The following is a description of a gene set: studied in species Homo sapiens Human Gene Set: HP_ABNORMAL_RESPIRATORY_SYSTEM_MORPHOLOGY Abnormal respiratory system morphology A structural anomaly of the respiratory system., and this is the list of marker genes: FSHR, CLCA4, CRIPTO, HLA-DRB1, RSPO1, SNRPN, PIK3R1, TBC1D8B (NCBI Gene Id 54885), CCND1, ZAP70, NELFA, CCN2, AIRE, DDX3X, NDUFB10, ZCCHC8, PIEZO2, NME5, TET2, PWRN1, SLC12A6 (solute carrier family 12 member 6), FLII, FCSK, TONSL, TRPV3, IFNGR1, AFF4, EVC, GCLC, OCA2, CHRM3, HPS6, FLNB, IL17F, WRAP53, KPTN, NUP205, ELANE, SHH, SP110, ATP6V1B2, SLC26A4, NIN, PSMB9, SCNN1A, TMCO1, CCNQ, UGP2, NIPAL4, FLCN, LMNB1, NLRP1, CCR2 (C-C motif chemokine receptor 2), DPAGT1, RREB1, REN, FBN2, HIRA, KIF20A, POLR2A (NCBI Gene Id 5430), HEY2, PKHD1, DLK1, KCNMA1, PSMD12, WBP11, EDN1, KLF1, PIGO, MDM2, PIGQ, DTYMK, SLC5A7, POLR1A, COL3A1, PRKACA, MYPN, MBTPS2, XPNPEP2, DIS3L2, MCM4, LIPN, MIR140, BMPER (NCBI Gene Id 168667), PEX1, SERPING1, PDGFRB, ARHGAP31, DSG1 (desmoglein 1), EWSR1, TAF1, GLB1, MLH1, PON2, SOX2, RIPK1, NEK9, PON1 (NCBI Gene Id 5444), PLVAP, DDX59, SNAI2, TRIM37, LIMK1, MRAP, COL5A2, BRIP1, EPHB4, KAT6A, SPINK1, BCL6, CD19, RIT1, BRCA1, FANCM, PRPH, POT1, CFH, SLC39A7 (NCBI Gene Id 7922), OCRL, GRIP1, SIAH1, MAGI2, LETM1, TCEAL1, SAT1, TP73, EMC1, PSAP, MANBA, PMS2, NEU1, OSTM1 (osteoclastogenesis associated transmembrane protein 1), VPS33A, ARPC1B, ERCC3, RNU4-2, PLCH1, TBC1D24, DPYSL5 (NCBI Gene Id 56896), POLR3A, POLE, NKX2-1, UFC1, STRA6, RPS15A, TRIM2, FGF20, MST1R (NCBI Gene Id 5755), ZNF341, TRAIP, SLC25A1, KMT2C, MAP3K7, MASP2, GAS8, MAP3K14, PRPS1, TCF3, ALX3 (NCBI Gene Id 93575), ABCA3, ETFA, NFASC, GIMAP5, CFAP74, BTNL2, ALPL, BLNK, CD3E, SPP1, PALB2, NOTCH1, CTSC (NCBI Gene Id 50958), LBR, SLC34A1, IL6R, CTNNBL1, TRIM8, VPS37D (NCBI Gene Id 171020), TNFRSF9, AGTR1, LPIN2 (lipin 2), ZNFX1, IRAK4, LRP12, RMRP, GRHL3, TRAF3IP1, PIGT, TMEM270, MPEG1, IL7R, PRKAR1A, SLC34A2, DAW1, DCLRE1C, SPEF2, SMC1A, ATXN2, DMXL2, FARSA, FCGR2A, PAX2, CEBPE, REST, RIN2, NKX2-6 (NCBI Gene Id 137814), WNT3, SCAF4, PRG4, GBA1, CCR1, H19, BRF1, FADD, ACE, MSN (moesin), SCN4A, DGCR2, PAK2, ARID1A, MARS1, ZIC2, CLPB, CR2, ATP6V0A2, CD2AP, CD46, KIAA0319L, EXTL3 (exostosin like glycosyltransferase 3), POU6F2, DPM2, CDKL5, ERCC4, PLEC, KDM6A, UFD1, DNAJB4, CHD6, GRIA1, COMT, FCGR2B, CSF2RB, KCNN4, VPS35L, IL23R, LRPPRC, AGGF1, ITGA8, TAOK1, MED12, LOX, RIPPLY2 (ripply transcriptional repressor 2), PIK3CA, IL17RC, CEP120, FLNC, FUCA1, ELF4, PIGA, ALG3, KIAA0753, NDN, NUP214, DEAF1 (NCBI Gene Id 105376508), TPM3, IL12A-AS1, MYD88, PRTN3, NME8, CTNNA2 (NCBI Gene Id 1496), SLC18A3 (solute carrier family 18 member A3), YARS1, CD79A, CNTN1, IL17RA, RAP1B (RAP1B, member of RAS oncogene family), SGCG, AGA, MRPS22, AGR2, AASS, FKBP6, MAPK1, TNNT2, KCNA1, SBDS, SMCHD1, EGFR, TBX4, SCN9A, IFT140, MSH6, EIF4A3, NOD2, DNAAF2, PTCH1, PAX3, MYO1E, DEPDC5, EPCAM, CFTR, SNORD116-1, DHCR24, LFNG, WRN, F12, GSTM3, DNASE1, CCDC22, GPC4, CLIP2, ERF, ARNT2, MEFV, ADAMTS19, CD40LG, HYLS1, PET117, DNAAF11, SPI1, FOCAD, NSD1, CSF2RA, NCF2, ACTA1, PMM2, DYNC2I2, NCKAP1L (NCBI Gene Id 3071), HGSNAT, ALDH1A2, UNG, SLC6A14, SLC11A1, TFG, SEMA3E, BACH2, SPTBN1, RSPH9, NTRK1, ERCC6, MMP1, UMPS, SPIDR, DNASE1L3, TIMM8A, TUBG1, JAGN1, MID1, GLMN, DICER1, PRDM10, H4C5, TXNDC15, TBC1D23, FBXO11, BUB3, SH2D1A, PPARGC1A, PIK3CG, CDT1, GIPC1, MGAT2, FGFR3, LTBP1, SMAD3, CD8A, SMN1, COQ8B, SERPINA1, SLC46A1, TBX1, SDCCAG8, NECTIN1, OPTN, RERE, POLD1, GUSB, MEIS2, SMARCD1, UBA2, BTK, CREBBP, BUD23, IFNG, HMOX1, AP3B1, EHMT1, IQSEC2, KIF21A, CDON, MIF, FAS, PRNP, CUX1, LMNA, MGP, STX1A, KIF11, FGFR1, SNAP25, NADK2 (NAD kinase 2, mitochondrial), LTBP3, TNFRSF1A, SNORD115-1, CARD10, IRF1, NPHS1, ARX, APOL1, ALMS1, RSPRY1, GMNN, SCN10A, POR, SOX11, CAV1, ADAMTS3, GLUL, C2CD3 (C2 domain containing 3 centriole elongation regulator), CACNA1C, TNFRSF13B, SKIC3, SHROOM4, SATB1, DGCR6, MYH6, DOCK8, IL2RG, IGBP1, TAF15, TGFBR1, DNAH1, CLEC7A, SCN1B, IGLL1, CACNA1B, BGN, SLC7A7, EDA, TAP2, TBL2, CALCRL, NLRP12, PMS1, CXCR4, PRKG1, IDH1, ANG, ACTN4, UBE2A, USB1, PSMC3IP, SOX3 (SRY-box transcription factor 3), TTC21B, TSPYL1, EXT1, TBX20, ALG9, LZTR1, NEFH, ESS2, IRF5, FUS, DNAAF5, VAMP1, TYR, ACBD6, MYO9A, KRAS, NR5A1, PTPRO (NCBI Gene Id 5800), DNAJC30, TAP1, PPP2R1B, WAC, GP1BB, CD79B, ABCA12, FANCF, NOP10, SLC12A2, CDKN2A, MYL2, TCTN3, HNRNPA1, HCK, F5, RNU4ATAC, ENG, HAAO, BRCA2, WDR35, PRRX1, ARHGDIA, APOE, SLC25A24, NEB, FLNA, HOXD13, NPHS2, SULT2B1, ABL1, DAAM2, KCNJ2, EMILIN1, USP26, SAMD9L, CHRNG, HSPG2 (heparan sulfate proteoglycan 2), SDHD, EPG5, SLC1A4, RTL1, PEPD, EFEMP2, FOXN1, CCR6, PTCD3, PAX6, ZBTB16, AICDA, EMG1 (NCBI Gene Id 619532), IL21, PRKCD, FANCD2, CRELD1, IRF8, GTF2IRD1, ORC6, EDNRB, RARA, MDM4, EBP, PYROXD1, NEPRO, ASXL1, COL4A5, PURA, ERBB4, XIAP, TSC2, CTSK, STX3, NGLY1, SCN11A, MAGT1, ACVRL1 (activin A receptor like type 1), TASP1, KLRC4, TARS1, SEMA4D, ODAD2, SFTPA2, APC2 (NCBI Gene Id 10297), IFT56, BMP4, PLP1, TCOF1, RFWD3, DNAL1, GFI1, MCIDAS, CTLA4, EHHADH, NXN, CCDC40, CHMP2B, FAM111B, SLC41A1, MAP3K8, DCTN4, FOXI1, NEK8, SCNN1G, ALDH18A1, ZNHIT3, CEP57, KRT5, ASXL3, RAI1, IKBKG, PNKP, DYM, H4C3, WARS2, NLRC4, B2M, SMARCB1 (SWI/SNF related, matrix associated, actin dependent regulator of chromatin, subfamily b, member 1), AMER1, LMOD3, PTPN11, H3-3A, KLHL40, NPAP1, GFRA1, NRCAM, MKS1, COQ7, TMEM260, COL11A1, SNIP1, LIFR, PTH1R, NODAL, HYDIN, DNAAF1, RSPH4A, PAICS, ZFPM2, SLC32A1, RAD51, POLR1B, CAPNS1, CYP27A1, ECM1, RRAS2, BAP1, C4B, ATRX, ODAD4, CILK1, NUP107, DNAAF3, USP18, PRSS1, FOXJ1, LACC1, CD3D, ARMC2, ACTC1, FOXP2, SYT2, MAP3K20, EMP2, IL10, NF1, PKD1L1, RAG1, SOX18, PEX13, CIITA, PIK3CD, FLT4, VPS51, CD247, SLC35A1, OAS1, AP3D1, TCIRG1, BLM, LRBA, SEC61A1, GPC3, LIG1, HES7, HPGD, LIG4, NAB2, HPS4, GAA, PLG, FRA10AC1, POLA1, SETBP1, SDR9C7, FAT4, RET, GSN, SRPX2, DNAH7, CCDC65, DOCK11, LAMB3, GAPVD1, SMPD1, JMJD1C, NOTCH3, THSD4, MEGF10, STAT1 (NCBI Gene Id 6772), HBB, CRB2 (crumbs cell polarity complex component 2), PLA2G6, LAMTOR2, SOD1, ERBB2, ASCC1, TRRAP, CRLF1, SOS1, UNC119, SMO, MYSM1, CHAT, TTC7A, SMARCA2, MRAS, FIG4, GABRG2, ORC1, RASA2, NHLRC2, FOXF1, NSMCE3, SMARCC2, RSPO2, PORCN, TARDBP, RAB3GAP2, PI4KA, TSC1, UBB, DISP1, LCK, BRD4, RALGAPA1, RAB27A, CAVIN1, FARSB, ADA2, SFTPC, SMARCA4, NOTCH2, CYBC1, POLR3H, NEUROD2, FBN1, DDR2, ELN, IDS, LAMA2, CYP4F22, PROKR2, ATM, LRIF1, WNT4, SPINK5, OFD1 (OFD1 centriole and centriolar satellite protein), STOX1, FGFR2, LMBRD1, NDUFAF6, BCL11A, RAB34, COL2A1, CASR, PLXND1, PPP1CB, UBA1, SAMD9, CFAP45, ASPRV1, CHEK2, METTL27 (NCBI Gene Id 155368, methyltransferase like 27), CBLB (NCBI Gene Id 868), MST1, C1QB, MAP2K1, COL13A1, PUF60, DIP2B, SNRPB, RAD51C, IL1RN, CARD11, DVL3, EP300, GLI1, COG4, MYCN, MPLKIP, RB1, UBE3B, MLX, XRCC2, KAT6B, FCGR3B, CFI, EXT2, TOM1, NFE2L2, SLC26A2, TIMMDC1, ADAMTS2, CTCF, PRKAG2, KMT2D, PCGF2, DOK7, CIROP, IRF4, CHD7, NUP160, SLC26A9, COLQ, CARMIL2, DCHS1, TFRC, PIGP, SIK1 (NCBI Gene Id 54018), PDCD1, LYST, LONP1, SELENON, MPDU1, ACP5, CD4, SLC22A18, FBLN5, MOGS, TBCD, TREM2, SQSTM1, SMAD2, HLA-DQB1, SMG8, HBG1, DLL1, PSMB8, TRPS1, TNNI3, AGT, TNFSF11, RFXAP, DNAJB13, NDUFC2, CHST14, LGI4, DNAJC21, FGF8, EXOSC9, DNMT3B, MSH2, SALL4 (spalt like transcription factor 4), ZFTA (zinc finger translocation associated), LAMB2, RARB, DOCK2 (dedicator of cytokinesis 2), TLR4, COL12A1, IGHG2, SREBF1 (NCBI Gene Id 6720), CCBE1, NUMA1, GALNS, SOCS1, IRF2BP2, DHCR7, HLA-DPB1, GATA2, DLL3, CD27, JAK3, RNF168, FASLG, PDE11A, PDHA1, TERT, RSPH3, PPP1R21, TMEM94, STAG2, GALC, DYNC2H1, RFT1 (NCBI Gene Id 91869), CSPP1, ZNF668, HERC2, MYL9, PKP1, ATP6V1E1, FANCL, SERPINH1, TNFSF12, CBL, TRIP13, FOXH1, CD55, PERP, CC2D2A, CHRNA1, ZMYND10 (NCBI Gene Id 51364), APC (NCBI Gene Id 324), PARN, CORO1A, CCNO, GORAB, SIM1, RASGRP1, GLI3, NHLRC1, RCBTB1, FOXC2 (NCBI Gene Id 50824), POLG, TAPBP, MAD2L2, EDNRA, TP63, ATP11A, ORC4, LTBP4, DNAI2, NKX2-5, GLDN, GREB1L, COL5A1, INTU, MLXIPL, LRP4, ARL2BP, ETFDH, ARID2, SPRED1, P4HA2 (NCBI Gene Id 8974, prolyl 4-hydroxylase subunit alpha 2), CD81, CDCA7, VCP, THOC2, RAPSN, GFM2, CD3G, IFT80, NIPA2, MYRF, CENPE, UHRF1, HFE, DKC1, MARS2, ARHGAP24, CFAP410, MT-CYB, MKRN3, TGIF1, SMARCD2, GLA, HLA-DQA1, PCNT, GAS1, MMP21, SYT1, DEF6, INVS, SOX4, PPM1D, PWAR1, INF2 (inverted formin 2), RAC1, DCTN1, NCF4, MYO1H, PIEZO1, TGM1, GEMIN4, SCNN1B, STXBP2, STK4, PRMT7, AGRN, MYMK, PIGG, WT1, CAT, ITGA3, CTC1, SCARF2, TUBA1A, COL17A1, BMPR2 (NCBI Gene Id 659), ODAD1, GATA6, GNAO1, MAN2B1, CDC45 (cell division cycle 45), FOXE3, TBK1, AAGAB, GLI2, DIAPH1, IFIH1, EFL1, RELB, EVC2, HELLS, SCARB2, BCL2, GRM7, NUP133, MECP2, WNT7A, TRAC, RYR1, FANCE, SLF2, RFX5 (regulatory factor X5), CYP2A6, LAMA3, CRTAP, WDR19, COL4A6, ANLN, LEPR, COL6A1, G6PC3, VHL, MYH11, PON3, UQCRH, CFAP53, FOXP1, TYK2, DSE, PDGFRA, ADARB1, TP53, TBL1XR1, PML, KDM5C, ARSL, NUP93, SKIC2, PANK2, IFT172, GUF1, MYH3, COPA, EIF4H, STIL, GPC6, UBAP2L, BCR, RAF1, SOX10 (SRY-box transcription factor 10), FUT8, CEP55, ICOS, LAT, BRAF, POLR1C, RNF125, FANCI, IL2RA, TGFB1, SATB2, MYBPC3, SLC52A3, STAT4, CTPS1, MCTP2, STAT3, ZBTB24, IL6ST (interleukin 6 cytokine family signal transducer), DONSON, ZNRF3, NAGLU, FRAS1, FREM2 (FRAS1 related extracellular matrix 2), RLIM, CASK, LAMC2, MESP2, FMO3, PAFAH1B1, TPP2, TGFB3, CCDC39, HRAS, IL21R, ROBO1, DLL4, PKDCC, P4HTM, LRRC56, KIF7, TNFRSF1B, KITLG, WASHC5 (NCBI Gene Id 9897), NSD2, TRAF3IP2, TBX6, KNSTRN, ATP6V0A1, CPLX1, RFC2, TBX3, RFX7, ALX1, VARS1, GTF2I, TTR, FGF10, IKBKB, SFTPB, KANSL1, H3-3B, COL4A3, SERPINF2, SNAP29, TECPR2, RNH1, MALT1 (NCBI Gene Id 10892, MALT1 paracaspase), BRWD1, SLC37A4, NUP85, RPGR, IPO8, ACVR2B, EOGT, CRKL, RBPJ, GPR35, FLI1, SLC29A3, GAS2L2 (growth arrest specific 2 like 2), NR1H4, PIGN, UNC13A, NBN, BCOR, MTHFD1, SPECC1L, STIM1, RIPK4, MYMX, RPA1, DOCK6, IGKC, TRPC6, CHUK, MTO1, RPL5, FCGR3A, SLC31A1, NEK1, ALOX12B, ARID1B, ALOXE3 (arachidonate epidermal lipoxygenase 3), NHP2, RRAS, CASP10, SLC25A22, BNC1, HNRNPR, HLA-DPA1, EFEMP1, HBG2, STAT5B, CTNNB1, ITCH, TAPT1, COG6, ALG12, NFKBIA, SMAD4, BCL10, BTD, WDR26, BMP2 (bone morphogenetic protein 2), MS4A1, TTC12, GATM, GTF2IRD2, KATNIP, TCF4, FLT1, STING1, GDF2, CEP295, FOXE1, CYBA, MUC5B, FAM13A, SYK, DPP9, POGZ, ITK, NPM1, TBX5 (T-box transcription factor 5), TAFAZZIN, IL6, USP9X, HLA-B, TGFB2, NCF1, OTUD5, TRIP4, IVNS1ABP (NCBI Gene Id 51489), ICOSLG, AKT1, MITF, SLC2A10, SOX9, GNPTAB, FERMT1, FOXP3, CD28, GTF2H5, TLL1, ACADVL, NDUFA6, COL14A1, PLOD1, CFAP298, IFT43, ZEB2 (zinc finger E-box binding homeobox 2), C3, NSDHL, GJA1, EIF2AK4, CCDC103, AARS1, B3GLCT, CCNF, ATP6V1A, MEG3, GDF1 (NCBI Gene Id 2657), PLD1, TYMS, SIX3, SPTBN4, TINF2, LRRC8A, IER3IP1, SOS2, SIX2, TNFRSF13C, SCN2A, NEK10, CAPN15 (calpain 15), RNF113A, HYOU1, ITPR1, ARHGEF1, CASP8, MDFIC, DPF2, SGSH, AK2, IRAK1, SH3KBP1, HK1, RPL10 (NCBI Gene Id 88324), TK2, SPRED2, MFAP5, OTX2, IRF9, BUB1B, RHOH, PSMB4, KIF22, BUB1, RAG2, BCL11B, STK36, CEACAM6, DZIP1L, DGCR8, CHCHD10, INPPL1, COL6A2, NAA10 (NCBI Gene Id 8260), NFKB2, RFXANK, KCNJ6, CEACAM3, FANCC, SRP19, BIRC3, DDRGK1, FBXO28, ADA, FANCA, MUSK, SCUBE3, ZIC3, RASA1, IL10RB, EPM2A, VAPB, UBE2T, HPS1, CTBP1, WNT9B, NOTCH2NLC (NCBI Gene Id 101060315), MSH4, ATP5F1A, DSP, AHDC1, NPHP3, DNAI1, ADAMTSL2, ANKFY1, SLC19A1, NRAS, MED25, IKZF1, ZMPSTE24, CARS1, MKKS, PRKDC, ANXA11, SLC35C1, TRIP11, AARS2, KEAP1, NIPA1, POLR1D, DYNC2LI1, ASAH1, NFIX, NAE1, ELP1, PRKACB, MAT2A, SALL1, ARPC5, TRAF7, PHIP, GRIN2A, GLE1, GATA4, FIP1L1, ETFB, CHRND, UBQLN2, MAGEL2, SUCLG1, IDUA, MYO5A, IL12B, DYNC2I1, KLHL41, PEX5, FCN3, RANBP2, PIGL, WDR1, ARVCF, HS3ST6, NUP37, SLC9A3, PRIM1, NIPBL, GTF2E2, UBAC2, DNAH11, PFN1, IGSF3, KIF1B, VANGL1, PRSS2, RILPL1, FUZ, TGFBR2, FANCB (NCBI Gene Id 2187), BMP15, REL, TREX1, SEC24C, SASH3 (SAM and SH3 domain containing 3), JAG1, LEP, ACTA2, ZBTB7A, RTEL1, FNIP1, VPS13B, CLCN7, IFT81, ALB, DNAAF4 (NCBI Gene Id 1867), MYOD1, MTM1, C4A, IL12RB1, RBM10, TPM2, BLTP1, STK11, CHAMP1, PTEN, ITGA7, PLCG2, FCHO1, STAT6, HACD1, NUP88, NFKB1, CDC42, TERC, GLT8D1, MYLK, BAZ1B, HELLPAR, CFAP52, WAS, PNP, B3GALT6, KIAA0586 (NCBI Gene Id 9786), COL7A1, DAO, PLCE1, ADNP, CFAP221, REEP1, CTRC, GPKOW, TBCE, FANCG, FMR1, EDARADD, PGM3, ALG14, WIPF1, SLX4, SF3B2, ROR2, NABP1, NPC2, ERAP1, KRT14 (keratin 14), SF3B4, MATR3, ARSB, ODAD3, ZSWIM7, CYBB, PRKN, SETD2, SON, SLC4A10, NAF1, GRIN1, TRPV4, IFT122, CFAP300, MYH7, IL12A, ADGRG6, ESAM, STN1, SLCO2A1, DNAH9, DNAAF6, WNT7B, IGHM, SFTPA1, TNFRSF11A, SPAG1, COL11A2, IL2RB, TRIM28, CORIN, CLXN, CFB, GNS, PHGDH, NOS1, ANO3, DNAH5, DRC1, ZNF699, SMARCE1, ERCC2, SFRP4, FBXW7, FREM1, POLD3, RSPH1, FAM20C, PTPN22, SNX10, HESX1, RUNX2, KCNJ10, CITED2, HDAC4 (histone deacetylase 4), RAC2